The following is a description of a gene set: electronically inferred by orthology from the curated human pathway part of: Cardiac conduction studied in species Mus musculus This event has been computationally inferred from an event that has been demonstrated in another species.<p>The inference is based on the homology mapping from PANTHER. Briefly, reactions for which all involved PhysicalEntities (in input, output and catalyst) have a mapped orthologue/paralogue (for complexes at least 75% of components must have a mapping) are inferred to the other species. Reactome Pathway: Phase 1 - inactivation of fast Na+ channels, and this is the list of marker genes: Kcnip4, Kcnip2